The following is a description of a gene set: from publication Cui A, Huang T, Li S, Ma A, Pérez JL, Sander C, Keskin DB, Wu CJ, Fraenkel E, Hacohen N (PMID 38057668) Mouse Gene Set: CUI_CDC1_IL10_RESPONSE_DN Cytokines mediate cell-cell communication in the immune system and represent important therapeutic targets. A myriad of studies have highlighted their central role in immune function, yet we lack a global view of the cellular responses of each immune cell type to each cytokine. To address this gap, the authors created the Immune Dictionary, a compendium of single-cell transcriptomic profiles of more than 17 immune cell types in response to each of 86 cytokines (>1,400 cytokine-cell type combinations) in mouse lymph nodes in vivo. A cytokine-centric view of the dictionary revealed that most cytokines induce highly cell-type-specific responses. For example, the inflammatory cytokine interleukin-1β induces distinct gene programmes in almost every cell type. A cell-type-centric view of the dictionary identified more than 66 cytokine-driven cellular polarization states across immune cell types, including previously uncharacterized states such as an interleukin-18-induced polyfunctional natural killer cell state. Genes negatively differentially expressed in cell type: cDC1 (conventional dendritic cell type 1) upon treatment with cytokine: IL-10 in mouse lymph nodes in vivo. studied in species Mus musculus, and this is the list of marker genes: Eef2, Pold4, Fosb, Igsf6, Irag2, Marcksl1, Actg1, Adrb2, H2-DMa, Pmaip1, Cd44, Fuca1, Arhgdib, Vim, Tm6sf1, Lyz1, Epb41l4aos, Slc46a3, Uba52, Tbc1d4, Bcl2a1d, Alcam, Klf2, Cyp27a1, Npc2, Tm9sf2, Zfp36l1, Pstpip1, Lyz2, Evl, Npm1, Nedd4, Eif3e, Cd83, Dusp1, Tsc22d3, Cox7a2l, Septin6, Ucp2, Clk1, Zfp36l2, Nop53, Cyb5a, Atf3 (activating transcription factor 3), Stk17b, Klf4, Cited2, Nr4a1, Niban1, Rgs2, Pcbp2, N4bp2l1, Rtl8a, Lpar6, Arsb, Cd180, Gdi2, Rgs10, Itga1, Serpinb6b, Lipa (NCBI Gene Id 16889), Pnrc1, Btg2, Ramp1, Gpi1, Unc119, Jun, Celf2, Hepacam2, Adgre5